The following is a description of a gene set: The chemical reactions and pathways resulting in the formation of a pyrimidine-containing compound, i.e. any compound that contains pyrimidine or a formal derivative thereof. Mouse Gene Set: GOBP_PYRIMIDINE_CONTAINING_COMPOUND_BIOSYNTHETIC_PROCESS studied in species Mus musculus, and this is the list of marker genes: Uck1, Tyms, Thtpa, Tbpl1, Dhfr, Nme5, Nme7, Upp1, Cad, Ak9, Umps, Nme6, Cda, Dut, Nme4, Ctps1, Uprt, Ctps2, Dctd, Slc25a19, Dhodh, Uck2, Upp2, Nme2, Shmt1, Tk1, Tpk1, Slc19a3, Cmpk2, Slc4a7, Dtymk, Dck, Nme1, Shmt2, Cps1, Uckl1, Slc19a2, Cmpk1, Mtor, Nme3